Given this list of marker genes Aoc1, Afdn, Cldn15 (claudin 15), Cldn4, Mxra8, Pof1b, Mapk15, Ctnnb1, Jam2, Epcam, Tjp3, Cdk4, Cldn10, Gm1123, Cldn34c5, Samt2b, Sapcd2 (suppressor APC domain containing 2), Strn, Clmp, Samt2, Cldn6, Lim2 (lens intrinsic membrane protein 2, NCBI Gene Id 233187), Lsr, Dsg3, Pard6a, Cldn20, Tjp1, Ect2, Rapgef2, Cdh5, Rap2c, Cldn14, Cyth3, Usp53, Cxadr, Dlg1, Eppk1, Arhgap17, Nphp1, C1qtnf5, Ocel1, Cldn19, Cldn23, Cyth1, Cldn1 (claudin 1), Cldn22, Cldn18, Cldn34b2, Cldn7, Amot, Ubn1, Tjp2, Cldn34a, Cldn12, Cldn34c3, Cldn9, Wwtr1, Frmd4a, Nphp4, Cgnl1, Ccnd1, Pard6g (par-6 family cell polarity regulator gamma, NCBI Gene Id 93737), Cldn34b1, Frmpd2, Gja1, Tbcd, Ank3, Ash1l, Wnk3, Cyth2, Cldn34c1, Gja6, Mtdh, Cldn2 (claudin 2), Sipa1l3, Actb, Amotl2, Cldn34c6, Wnk4, Traf4, F11r, Synpo, Samt1b, Cldn34c4, Marveld3, Tjap1, Cldn24, Adcyap1r1, Plxdc1, Cldn13, Pard6b, Lin7a, Ildr1, Frmd4b, Map3k1, Jam3, Ccdc85c, Patj, Cldn17, Pard3, Lin7b, Sh3bp1, Pmp22, Rab13, Cgn, Prkci, Rap2b, Samt4, Bves, Mpp7, Samt3, Atp7b, Magi2, Fzd5, Cldn34d, Cldn11, Dlg3, Luzp1, Mpdz, Cldn8, Micall2, Arhgef2, Prkcz2, Vasp, Cldn34c2, Amotl1, Crb3, Ildr2, Cntnap1, Magi1, Shroom2, Cldn5, Rpgrip1l, Cldn3, Jaml, Rigi, Sympk, Ocln, Igsf5, Cldn34b4, Magi3, Marveld2, Prkcz, Epb41l4b (erythrocyte membrane protein band 4.1 like 4b), Pals1, Tgfbr1, Apc, Ctnnd1, Esam, Samt1d, Pdcd6ip, Cldn34b3, Cldn25, Nfasc, Cldn16, Lin7c, Vapa, Yap1, Pard3b, Epha2, here is a description of the gene set: species: Mus musculus A cell-cell junction that seals cells together in an epithelium in a way that prevents even small molecules from leaking from one side of the sheet to the other. Mouse Gene Set: GOCC_TIGHT_JUNCTION